The following is a description of a gene set: Genes having at least one occurrence of the motif GNNKACGTGCGGNN in the regions spanning 4 kb centered on their transcription starting sites. This matches the HIF1A transcription factor binding site V$HIF1_Q3 (v7.4 TRANSFAC). species: Homo sapiens Human Gene Set: HIF1_Q3, and this is the list of marker genes: PRDM13, DOT1L, RUVBL2, USF2, AMPD2, RAB10, BCL2L11, XRN2, IGF2BP3, MACO1 (macoilin 1), AP3M1, BCL11B, NXPH1, TBC1D20, PPT2, IGF2BP1, DDIT4, PTEN, ZSWIM9, DSCAML1, BCL6, FAM114A1, NRF1, RAMP2, KDM3A, LIG1, ERO1A, ZNF800, TXLNG, TSSK3, JADE1, XPNPEP1, ST6GAL1, CA9, USP37, TMEM88, LDHA, PSME3, KLHDC3, KTN1, SLC12A4, CLUH, JPH1 (NCBI Gene Id 56704), PGK1, COX4I2, MAX, P3H3, ELOVL6, ITCH, TEF, ZNF771, DERL1, PPP1R3C, VEGFA, ALDH1A2, EED, IKZF2, SORCS3, PIK3IP1, LTBP1, ZIC2, SRSF6, PES1, COPZ1, RAB33A, KLF11, ZNF827, MRTO4, SPOP, ATOSB, C11orf71, RTRAF, PDP2, MGLL, EML1, JADE2, CNOT9, NPR3, GCSH, AGAP1, ENTPD7, UTP18, NUP98, DSCAM, GOLT1B, BCL11A, CNPY3, ERF, TBC1D8B, HIF3A, ZBTB47 (NCBI Gene Id 92999), GYS1, MYLK, PSD, REV1, EN1, PABPC1, GRIN2A, ATP1B3 (NCBI Gene Id 483), TRPC4AP, KCTD15, RBM7, GBE1, FGF10, G6PC3, EIF4G1, LMF2, NTMT1, BRWD3, HMGN2, EPB41L4B, FGF6, GOLGA4, AARSD1, HYAL2, FCHSD2, DERL3, TMEM132E, FGF17, NCAPH2, RFX5, PRKAR2A, HNRNPUL1, LRRTM1, CCDC126, CREBRF, ZZZ3, SNCB, BMP6, HMGXB4, INSM1, YBX1, CLSTN3, SLC37A4, LHX5, C17orf58, NR2F2, RPL22, NRBF2, TLL1, TFRC, GPM6B, BHLHE41, RCOR2, SLC26A10P (NCBI Gene Id 65012), ADK (NCBI Gene Id 132), BNIP2, RECQL, TSKU, HMGA1, ZBTB10, RUNDC1, EPHB3, PGM3, ZBTB37, TRIM3, ING3, SOX14, MID1IP1, LRP2BP, CEP85, IRF2BP1, TMTC1, AK3, PPRC1, STMN1, MEF2C, STC1, SOX2, TMEM132E-DT, RWDD2A, TLNRD1, TIAL1, ERLIN1, ESRRA, SCYL1, PATZ1, EMC1, NAV2, FGF11, MGME1, PDGFB, DUSP7 (dual specificity phosphatase 7), PRMT1, UQCC2, ABI2, NANS, QRICH1, BMAL1, HBEGF, UBA1, KICS2, SRSF1, SLC12A5, ERLEC1 (NCBI Gene Id 27248), POLA1, ASB3, KDM4B, SNX12, CITED2, KMT2E, BCL2, KLHL35, PHF12, SLC6A1, DDX4, FKBP3, MICAL2, HOXA7, SCAMP2, AGPAT1, YEATS2, RNF5, ENO1, UBXN10, SRFBP1, PRDX4, MPL, PPM1E, NR1D1, LRP8, PTPRF, PDK3 (pyruvate dehydrogenase kinase 3), SHISA6, SAMTOR, CCND2, SRSF5, POLR3E, NFIL3, TRIM33, TET2, IRF2BPL, E2F3, RGS16, RUNX1T1, SNX5, MEA1